Given this list of marker genes Ccl21a, Mpp1, Cmklr1, Zfp580, Cyp19a1, Vegfc, Ninj1, Serpine1, Il23a, Trem1, Lyn, Fpr2, Padi2, Ptk2 (PTK2 protein tyrosine kinase 2), Ccr2, Dpp4 (NCBI Gene Id 13482), Rin3, C3ar1, Il4 (NCBI Gene Id 16189), Ccr1l1, Rarres2, Ednra, Ccn3, Gas6, Cxcl10, Lbp, F2rl1, Stap1, Thbs1, Aif1, Swap70, Edn1, Ptk2b, Slit2, Dysf, Stk39, Vegfd, Mst1, Ccl19-ps1, Vegfa, Fpr-rs7, Pgf, Dusp1, BC037156, C5ar2 (NCBI Gene Id 319430), S100a14, Slc8b1, Ccl19-ps6, Mapk1, Sell, Slamf1, Gpr18, Ppbp, Spi1, Mcu, F7, Mif, Ccl21d, Pla2g7, Ccl19, Nckap1l, Nedd9, Jam3, Calr, Fpr-rs6, Dapk2, Hc, Creb3, Thbs4, Klrk1, Lgmn, Cx3cr1, Adam17, Ccl19-ps5, Dnm1l, Trpv4, Defb25 (defensin beta 25), Ccl1, Gpsm3, Wnt5a, Mtus1, Slamf8, Il34, C5ar1, Cxcr2, Mapk3, Ripor2, Ccr7, Edn3, Ptn, Vegfb, Cxcl14, Ccl3, Xcl1, Tnfsf18, Bst1, Oxsr1, Cxcl12, Ccr1, Ccl7, Tnfaip6, App, Ccl5, Camk1d, Fpr-rs3, Adam10, Il1b, Ccl2, C1qbp (NCBI Gene Id 28127), Mdk, Ptprj, Cd74, Tnfsf14, Csf1, Il12a, Wnk1, Rac1, Ano6, Nod2, Mstn, Ccl21e, Cx3cl1, Ccl21b, Ccl19-ps3, Akirin1, Mmp28, Ccl19-ps4 (C-C motif chemokine ligand 19, pseudogene 4), Mospd2, Csf1r, Fpr-rs4, Tmem102, Lgals9, Rac2, Ccr6, Cxcl17, Hmgb1, Cxcl13, Perp, Grem1, Tirap, Ccl12, Ccl21f, Nbl1, Edn2, here is a description of the gene set: studied in species Mus musculus Any process that modulates the frequency, rate, or extent of leukocyte chemotaxis. Mouse Gene Set: GOBP_REGULATION_OF_LEUKOCYTE_CHEMOTAXIS